The following is a description of a gene set: Absence or underdevelopment of the lens. Aplasia/Hypoplasia of the lens Human Gene Set: HP_APLASIA_HYPOPLASIA_OF_THE_LENS studied in species Homo sapiens, and this is the list of marker genes: CPAMD8, FOXC1, TONSL, RRAGC, XYLT2, FGF3, FBN1, FBXW11, FOXE3, LTBP2, PRR12, NDP, TRIM44 (NCBI Gene Id 54765), COL2A1, ADAMTS10, PAX6, MT-CYB, HMX1, ADAMTS17, LMX1B